Given this list of marker genes LAMA1, LAMA2, LAMB1, NID1, LAMC1, LAMB2, here is a description of the gene set: Human Gene Set: GOBP_REGULATION_OF_BASEMENT_MEMBRANE_ORGANIZATION species: Homo sapiens Any process that modulates the frequency, rate or extent of the assembly, disassembly or arrangement of constituent parts of the basement membrane.